Given this list of marker genes C8orf33, SLC7A1, ASPM, FERMT2, PPP2R5A, H1-4, FGF14-AS2, N4BP3, ALMS1P1, KCNA10, GPR26, HOXB-AS3, EQTN, HMX2, SLC28A2, FAM43A, WNT6, ANK2, VPS13A, KIT, G3BP1, SLC13A5, FKBP11, DLAT, HCFC2, PPDPF, CCR6, OR5H1, TMEM132B, IL23R, PPP4R3C (protein phosphatase 4 regulatory subunit 3C), RGS11, STK17B (NCBI Gene Id 9262), ATG4D, GML, ARHGAP36, ROPN1L, CDH7, PRKDC, JADE1, ENSG00000291065, RORC, ZNF644, CDC14A, INO80E, FMNL1, TSHZ1, RNF126, CRYGD, TRPC4, GPRIN3, LINC01845, SMG6, PRELID3B, LSM4, FBXO36, MAF, PITPNM2, PPIB, UGT1A6, PTPRCAP, KLRB1, FEN1, TRIL, TUSC2, WDTC1, LHFPL3-AS1, LINC01777, MYF6, EIF4G1, IL34, PIERCE1, NOXRED1, FBXO45, BTN2A3P, KLRG1, HS6ST3, FAM83E, MATN2, DRC3, H4C11, SUPT3H, DPP4, DSCAML1, RNF6, RXFP1, SFTPC, SNORA74A, AIRIM, ADAMTS1, MXD4, CACNA2D1, FAAP20, ILF3-DT, ENPP1, ELL, NWD2, CLPTM1, SKIL, LPCAT3, POLR2C, ENGASE, HCG18, ODF2L, DEFT1P, B4GALNT3, FOXRED2, SURF4, DLG5, RBM48, RIIAD1, MRPL12, DTNB, ENSG00000291179, FGF17, MPZL3, KMT2D, MUSK, ELF5, SCARNA17 (small Cajal body-specific RNA 17), MAPK8IP2, RDH13, LINC02481, LARP1B, CYP4F29P, CSPG4BP, IQCC, SLAMF1, RAB8B, FAM13C, SLC15A1, FIGN, SOX17, CFAP68, DNAJC5G, C16orf89, HOXA7, DQX1 (NCBI Gene Id 165545), TCP10L3, DSG4, JUN, TTTY10, DHCR7, TMEM263, LINC02591, BVES, FAM3D, HTR6, INO80B, ANKRD36, RDH10, LECT2, GSX1, GFPT1 (glutamine--fructose-6-phosphate transaminase 1, NCBI Gene Id 2673), TAS2R10, TBX18, MED19, CARD11, NEUROD1 (neuronal differentiation 1), OR1I1, CCSAP, ITPR3, SCART1, IL17RE, SCUBE3, RAB4A, CNDP1, NCR3, NDRG2, LINC00612, LINC01120, LCTL, ZMYND19, MTMR9LP, B3GALNT1, MUC4, IL32, SRRM2, TMEM184B, SPOCK2, EPB41L4B, RBM27, WFDC10A, GPD1L, RC3H1, RNF115 (ring finger protein 115), FAP, ANK1, SI, FENDRR, here is a description of the gene set: from publication Schenk M, Krutzik SR, Sieling PA, Lee DJ, Teles RM, Ochoa MT, Komisopoulou E, Sarno EN, Rea TH, Graeber TG, Kim S, Cheng G, Modlin RL (PMID 22447076) Genes up-regulated in monocytes (24h): untreated versus muramyl dipeptide. human blood monocytes were isolated, activated and harvested at several timepoints In this study, we identified genes that were differentially expressed in human monocytes activated with eiter NOD2L and/or TLR2/1L. studied in species Homo sapiens Human Gene Set: GSE34156_UNTREATED_VS_24H_NOD2_LIGAND_TREATED_MONOCYTE_UP